Given this list of marker genes SCD, AZGP1, HMGCS1, INPP4B, PDLIM5, KRT19, PALM2AKAP2, PIAS1, ABCC4, TPD52, SLC26A2, APPBP2, AKAP12, CPD, ADAMTS1, DBI, RAB4A, ALDH1A3, C1orf21, UGDH, HES6, SMS, SLC38A2, DNAJB9, FKBP5, H1-0, SELENOP, LIFR, PGM3, ZBTB10, HOMER2, MYL12A, SRP19, ABHD2, B2M, TMPRSS2, ACSL3, NDRG1, ADRM1, TNFAIP8, ELL2, KRT8, MAF, SNAP25, ORM2, KLK4, PHYH, CAMKK2, RBM10, DHCR24, HERC3, SGK1, IQGAP2, VAPA, IDI1, HSD17B14, ACTN1, DCTN3, TSC22D1, KLK3, CDC14B, SAT1, STEAP4, KLK2, PTPN21, KLF4, LMAN1, GUCY1A1, ID2, NKX3-1, PMEPA1, SEC24D, PLPP1, ITGAV, SPDEF, UAP1, SORD, GSR, STK39, B4GALT1, ELOVL5, UNC13B, HPGD, here is a description of the gene set: studied in species Homo sapiens from publication Nelson PS, Clegg N, Arnold H, Ferguson C, Bonham M, White J, Hood L, Lin B (PMID 12185249) Human Gene Set: NELSON_RESPONSE_TO_ANDROGEN_UP Genes up-regulated in LNCaP cells (prostate cancer) in response to synthetic androgen R1881. The human prostate gland is an important target organ of androgenic hormones. Testosterone and dihydrotestosterone interact with the androgen receptor to regulate vital aspects of prostate growth and function including cellular proliferation, differentiation, apoptosis, metabolism, and secretory activity. Our objective in this study was to characterize the temporal program of transcription that reflects the cellular response to androgens and to identify specific androgen-regulated genes (ARGs) or gene networks that participate in these responses. We used cDNA microarrays representing about 20,000 distinct human genes to profile androgen-responsive transcripts in the LNCaP adenocarcinoma cell line and identified genes with transcript alterations more than 3-fold. Of these, 103 encode proteins with described functional roles, and 43 represent transcripts that have yet to be characterized. Temporal gene expression profiles grouped the ARGs into four distinct cohorts. Five uncharacterized ARGs demonstrated exclusive or high expression levels in the prostate relative to other tissues studied. A search of available DNA sequence upstream of 28 ARGs identified 25 with homology to the androgen response-element consensus-binding motif. These results identify previously uncharacterized and unsuspected genes whose expression levels are directly or indirectly regulated by androgens; further, they provide a comprehensive temporal view of the transcriptional program of human androgen-responsive cells.